The following is a description of a gene set: from publication Chaussabel D, Semnani RT, McDowell MA, Sacks D, Sher A, Nutman TB (PMID 12663451) Genes down-regulated in comparison of dendritic cells exposed to L. major versus macrophages exposed to L. major. Monocyte-derived dendritic cells (DC) and macrophages (MΦ) generated in vitro from the same individual blood donors were exposed to five different pathogens, and gene expression profiles were assessed by microarray analysis. Responses to Mycobacterium tuberculosis and to phylogenetically distinct protozoan (Leishmania major, L. donovani, Toxoplasma gondii) and helminth (Brugia malayi) parasites were examined, each of which produces chronic infections in humans yet vary considerably in the nature of the immune responses they trigger. Human Gene Set: GSE360_DC_VS_MAC_L_MAJOR_DN studied in species Homo sapiens, and this is the list of marker genes: CREBBP, PHACTR4, MICA, PPP1R12B, SKAP1, MERTK, SLC4A3, PPP2R2B, HIC1, PARVA, ZNF142, FOXC2, CCK, NDUFB8 (NADH:ubiquinone oxidoreductase subunit B8), GPRIN2, FOXM1, MEF2D, ZBTB25, CCL1, FAM131B, SEL1L, SDC4, SLC10A2, AGFG1 (NCBI Gene Id 3267), MPHOSPH10, DLG4, TFR2, EIF4E, ZBTB20, RAB40AL, CRTAM, GCNT2, WRN, PLRG1, SYN2 (NCBI Gene Id 6854), BAZ2B, PPP1R10, PLSCR1, PIP5K1B, DCLRE1A, KLHL23, USP6NL, LDOC1, TFIP11, RPL39, DFFA, APLNR, PNOC, ENPEP, TSC22D3, LCP2, SEC24D, TAF1C, RNF114, LHFPL2, GPR17, OAZ2, NUP188, NXF1, POLD2, MPDZ, STIP1, S100A9, CACNA1C, DGCR2, ERCC1, FSCN2, SEMG1, PRDM1, CHRNA5, ERCC6, AATF, CD79B, PCCA, RORA, GLG1 (golgi glycoprotein 1), POM121L9P, CAMTA1, GUCY2F, ZG16, CYP11B1, LECT2, EMILIN1, CHD1L, APOBEC3B, ALDOA, FBLN1, FCGR3A, FLT4, PRPF19, RAB6A, APOH, TRIM24, MDN1, ALPI, CPNE1, DDX52, CKS2, WAS, RFC2, CAMP, INE1, PLA2G1B, PCMT1, RAB4B, SLC16A2, SRR, NPAT, ERCC5, NOTCH4, FASTKD2, H2AC17, CHRDL1, MYH11, TBP, GABRB1, REN, S1PR2, SREK1IP1, PRCC, OMG, FCHO1, FPGS, CDC42EP4, HMGB3P30, N4BP2L2-IT2, SREBF2, BSG, TRIAP1, IL18R1, MPHOSPH8, RPS11, ZNF197, SLC27A2, NUP153, SLC17A7, AFDN, KANK3, SEMG2, DHCR7, LIAS, PLEKHO2, GAA, PLXND1, TYRP1, MMS19, SST, DMXL1, NHP2, PMVK, TWIST1, TARBP2, FOS, SRPX2, SLC18A2, FAS, CNPY3, SERPINA5, EIF2S3, LANCL1, GAPVD1, SLC25A26, TNFRSF13B, PRRG1, SLC1A2, GRPEL1, SMAGP, MARCHF6, ZSCAN9, MEOX2, TTC28, BRCA1, CMKLR1, DYNC1I1, CCDC144A, SCN5A, PMPCB, GNGT1, CLDN7, MYH2, JADE2, SHANK2 (NCBI Gene Id 654128), HEG1, LCAT, KIF1B, PER1, MAPRE3, RUVBL1, NUP133, ILRUN, PGM5, ARHGAP44, POU1F1, ADNP2, MKNK2, BET1, GCDH, EPHA5, OLFM1